The following is a description of a gene set: Human Gene Set: ZHONG_PFC_C6_PLXNA4_POS_EXCITATORY_NEURON studied in species Homo sapiens from publication Zhong S, Zhang S, Fan X, Wu Q, Yan L, Dong J, Zhang H, Li L, Sun L, Pan N, Xu X, Tang F, Zhang J, Qiao J, Wang X (PMID 29539641), and this is the list of marker genes: SCG2, SRM, EIF1B, GNAL, CCBE1, PLXNA4, LINC01102